Given this list of marker genes FOLR1, MTHFD1, GCH1, SLC46A1, ATIC, DHFR2, DHFR, MTHFD1L, DHFRP1, here is a description of the gene set: studied in species Homo sapiens The chemical reactions and pathways resulting in the formation of tetrahydrofolate, 5,6,7,8-tetrahydrofolic acid, a folate derivative bearing additional hydrogens on the pterin group. Human Gene Set: GOBP_TETRAHYDROFOLATE_BIOSYNTHETIC_PROCESS